The following is a description of a gene set: studied in species Mus musculus A MAPK cascade containing at least the ERK5 MAP kinase (MAPK7; also called BMK1). It starts with the activation of a MAP3K, and the consecutive activation of a MPK2K and of ERK5. The cascade can also contain an additional tier: the upstream MAP4K. The kinases in each tier phosphorylate and activate the kinases in the downstream tier. The ERK5 cascade is activated by stress, mitogens, and by G protein-coupled receptors, and results in cellular responses such as cell growth, cell differentiation and development. Mouse Gene Set: GOBP_ERK5_CASCADE, and this is the list of marker genes: Alkal1, Rap1gds1, Map2k5, Mef2a, Rac1, Alkal2, Mapk7